The following is a description of a gene set: DNA double-strand break (DSB) response involves sensing of DNA DSBs by the MRN complex which triggers ATM activation. ATM phosphorylates a number of proteins involved in DNA damage checkpoint signaling, as well as proteins directly involved in the repair of DNA DSBs. For a recent review, please refer to Ciccia and Elledge, 2010. species: Homo sapiens Reactome Pathway: DNA Double Strand Break Response part of: DNA Double-Strand Break Repair, and this is the list of marker genes: H2BC13, H2BC11, UBXN1, SMARCA5, UBE2V2, RNF8, BABAM2, NBN, NSD2, MRE11, EYA1, ABRAXAS1, H2BC5, H4C1, KDM4A, H2AX, UIMC1, RNF168, PIAS4, H2BC15, H2BC26 (NCBI Gene Id 128312), ABL1, TP53, TP53BP1, UBA52, H3-4, HERC2, EYA4, H2BC14, EYA2, UBE2N, H2BC17, H2BC9, BABAM1, APBB1, H2BC21, RAD50, KDM4B, BRCC3, UBC, PPP5C, CHEK2, BARD1 (BRCA1 associated RING domain 1), SUMO1, EYA3, H2BC4, ATM, BAZ1B, BAP1, UBB, BRCA1, H2BC12L, KAT5 (NCBI Gene Id 10524), MDC1, H2BC3, UBE2I, MAPK8, RPS27A, H2BC1, KPNA2, H2BC12 (H2B clustered histone 12)